Given this list of marker genes CCDC106, DAZ3, TWIST1, DAZ1, GMPPB, ZFP36L1, ZNF827, RHOT1, PPP3R1, HERC4, RAB1A, ARX (aristaless related homeobox), ZFP91, PML (NCBI Gene Id 5371), HECW2, STRN3, RGS12, FGF1, MKLN1, DDX3X, NF2 (NF2, moesin-ezrin-radixin like (MERLIN) tumor suppressor), UBE2Q1, UBE2V2, ACP4, TGFBR1, CPEB2, IL1A, ARHGAP36, ARRB1, NAMPT, PSME3, CNPY3, RNF40, PHF6, ICA1, OGT, CDK6, ONECUT1, DNER, THRAP3, DRD3, CCSER2, PRKCQ, SAMTOR (S-adenosylmethionine sensor upstream of mTORC1), NPHP3, WDR97, DIO2, NRBF2, MED20, CRIM1, THAP1, PTGES2, PSMF1, ELMOD3, ASTN1, HMG20A, CD200R1, SLITRK4, HHIP, AKIRIN1, ROBO1, CEP83, CAPN3, NSF, TARP, CHODL, MLLT10, DAZ2 (deleted in azoospermia 2), DAZ4, PCDH17, MTUS1, HSD11B2, MPZ, PDIA6, FRMPD4, ZFHX4, here is a description of the gene set: Genes having at least one occurence of the motif CTCAAGA in their 3' untranslated region. The motif represents putative target (that is, seed match) of human mature miRNA hsa-miR-526b (v7.1 miRBase). Human Gene Set: CTCAAGA_MIR526B species: Homo sapiens